The following is a description of a gene set: part of: Developmental Cell Lineages of the Integumentary System The interfollicular epidermis is the skin surface layer in between the adnexa (hair follicles, sweat glands, and sebaceous glands). Going from the dermal epidermal junction, the interfollicular epidermis strata include the basal layer (stratum basale), spinous layer (stratum spinosum), granular layer (stratum granulosum), and the cornified layer (stratum corneum). The basal layer consists of keratinocyte stem cells and transit amplifying cells. The spinous, granular, and cornified layers consist of spinous keratinocytes, granular keratinocytes, and corneocytes, respectively. Interfollicular epidermis has a high cell turnover rate. Keratinocyte stem cells self renew throughout adulthood and give rise to transit amplifying cells. Transit amplifying cells undergo several cell cycles before committing to differentiation, first into spinous layer keratinocytes, then into granular layer keratinocytes, and finally into corneocytes. Corneocytes lose their nuclei and cytoplasmic organelles, forming flattened squames that provide a physical barrier against the invasion of pathogens and loss of bodily fluids. For a detailed review, please refer to Zijl et al. 2022, and for the single cell transcriptomic and spatial transcriptomic studies that provide a higher resolution view of human interfollicular epidermis, please refer to Cheng et al. 2018, Wang et al. 2020, Aragona et al. 2020, Haensel et al. 2020, Negri et al. 2023, and Ganier et al. 2024).<br><br>The cell lineage path of keratinocytes in interfollicular epidermis is depicted through four cell differentiation steps involving five distinct cellular states: keratinocyte stem cells of epidermal basal layer, transit amplifying cells, spinous keratinocytes, granular keratinocytes, and corneocytes. Each differentiation step is regulated by a distinct combination of regulatory molecules present in the microenvironment of differentiating cells. studied in species Homo sapiens Reactome Pathway: Differentiation of Keratinocytes in Interfollicular Epidermis in Mammalian Skin, and this is the list of marker genes: EGF